The following is a description of a gene set: Mouse Gene Set: CUI_MIGDC_TNFA_RESPONSE_DN Genes negatively differentially expressed in cell type: MigDC (migratory dendritic cell) upon treatment with cytokine: TNF-α in mouse lymph nodes in vivo. Cytokines mediate cell-cell communication in the immune system and represent important therapeutic targets. A myriad of studies have highlighted their central role in immune function, yet we lack a global view of the cellular responses of each immune cell type to each cytokine. To address this gap, the authors created the Immune Dictionary, a compendium of single-cell transcriptomic profiles of more than 17 immune cell types in response to each of 86 cytokines (>1,400 cytokine-cell type combinations) in mouse lymph nodes in vivo. A cytokine-centric view of the dictionary revealed that most cytokines induce highly cell-type-specific responses. For example, the inflammatory cytokine interleukin-1β induces distinct gene programmes in almost every cell type. A cell-type-centric view of the dictionary identified more than 66 cytokine-driven cellular polarization states across immune cell types, including previously uncharacterized states such as an interleukin-18-induced polyfunctional natural killer cell state. studied in species Mus musculus from publication Cui A, Huang T, Li S, Ma A, Pérez JL, Sander C, Keskin DB, Wu CJ, Fraenkel E, Hacohen N (PMID 38057668), and this is the list of marker genes: Btg2, Csf2rb2, Phf11b, Cxcl16, Nav1, Fos (FBJ osteosarcoma oncogene, NCBI Gene Id 14281), Sat1, Jund, Hspa1b, Dek, Slamf7, Trim7, Mycbp2, Lmo2, Arl5a, Lmo4, Tcf7l2, Ubc, Arhgap17, H2-M2, Adm, Fosb, H2bc4, St8sia6, Rassf4, Zfp36l1, Tnfrsf1b, Rgs3, Rasa4 (NCBI Gene Id 54153), Mx1, Jun, Mxd1, Laptm5, Zc3h12c, Chka, Spire1, Gtf2a1, H2ac25, Klf2, Hspa1a, Eno3